Given this list of marker genes PHLDA1, GLE1, VRK1, NNT, WDR55, IGF1R, SLC35A4 (NCBI Gene Id 113829), NUDC, PAK1, ATP8B4, ANKRD13B, KIF2A, REXO2 (NCBI Gene Id 51640), HPRT1, SH3BP5, KIF20B, ZFAND1, FNTB, SEC61A1, COL5A1, ALOX15, TOMM40, DNAJC24, VARS1, KNTC1, LAIR1, TIPIN, FKBP4, EMILIN1, UGGT1, TOPBP1, PRIM2, NAP1L1, PITPNB, PANK1, EEF1E1, SUCLG2, TRMT1, MORF4L2, USP14, MSH2, XKR5, METTL24, FGF13, SAC3D1, TTC21B, ABCG2, PIGX, PTGES3, PNO1, OXSM, SOWAHB, DIS3, PAK1IP1, CAD, PPIL3, RPN1, NARS2, CHEK1, ATIC, NUP188, RSRC1 (arginine and serine rich coiled-coil 1), TOP2B, EIF4B, GSAP, SERBP1, CDC123, BUB3, TSEN54, COPRS, CD200R1L, MCM5, TIMM10, DARS1, FASN, SLC5A6, LMNA, C19orf48P, TBC1D2B, UBTF, BAMBI (NCBI Gene Id 25805), RRS1, MYADM, HEATR1, MYO19, PHTF2, PSMG2, TSFM, MANF, METTL16, CERS2, MYO1E, MAP4K5, CDR2, MAGOHB, YARS1, EMG1, FOXK2, TNF, CIMAP1A, SLC25A17, MCM3, RAD54L, RAP1A, CENPQ, EIF5A2, TPGS2, PSMD13, TCF3, FIRRE, SMDT1, ADAM17, CXCL3, CD48, PRXL2C, SETD6, PRMT7, KYAT3, GCSH, COTL1 (coactosin like F-actin binding protein 1), RNF150, ANGPTL4, CD163, DDHD2 (NCBI Gene Id 23259), TOP1MT, GLRX5 (glutaredoxin 5), MYCBP, PIN1 (NCBI Gene Id 5300), NUP37, FERRY3, PPA2, MBOAT1, ZMAT3, DIMT1, RRP15, SUCLG1, RRP1B, PALD1, MTAP, EIF3G, NCS1, CMKLR2, ORC6, CTPS1, HSPBP1, CLSTN1, CCT4, WDR18, PRPF31 (NCBI Gene Id 6106), UTP18, DFFB, DIAPH3, NPEPL1, NIP7, RUVBL1, NAF1, FAM217B, ABRACL, ARHGDIB, P4HB, RPS27L, OSGEP, NDUFAF2, POP1, IRF4, PRPS1, MCM4, RANBP1, UBTD2, TTC13, MDC1, YDJC, PAN3, DDX39B, METTL1, UBE2N, LIG1, PRC1, ATP5MC3, CREG2, YEATS4, MRPL20, COPS3, ATAD5, SREBF2, FUS, KIF23, TCP1, HINT1, HMGCS1, TMX4, CLEC5A, PPAT, SAMM50, TMEM109, H2AZ1, EMC6, NDUFA8 (NADH:ubiquinone oxidoreductase subunit A8), EMB, here is a description of the gene set: species: Homo sapiens Human Gene Set: GSE22432_CONVENTIONAL_CDC_VS_PLASMACYTOID_PDC_UP Genes up-regulated in dendritic cells: common versus plasmacytoid. from publication Felker P, Seré K, Lin Q, Becker C, Hristov M, Hieronymus T, Zenke M (PMID 20881193) Dendritic cells (DCs) in lymphoid tissue comprise conventional DCs (cDCs) and plasmacytoid DCs (pDCs) that develop from common DC progenitors (CDPs). CDPs are Flt3+c-kitintM-CSFR+ and reside in bone marrow. Here we describe a two-step culture system that recapitulates DC development from c-kithiFlt3-/lo multipotent progenitors (MPPs) into CDPs and further into cDC and pDC subsets. MPPs and CDPs are amplified in vitro with Flt3 ligand, stem cell factor, hyper-IL-6 and insulin- like growth factor-1. The four-factor cocktail readily induces self-renewal of MPPs and their progression into CDPs and has no self-renewal activity on CDPs. The amplified CDPs respond to all known DC poietins and generate all lymphoid tissue DCs in vivo and in vitro. Additionally, in vitro CDPs recapitulate the cell surface marker and gene expression profile of in vivo CDPs and possess a DC-primed transcription profile. Transforming growth factor-β1 (TGF-β1) impacts on CDPs and directs their differentiation towards cDCs. Genome-wide gene expression profiling of TGF-β1-induced genes identified transcription factors, such as interferon regulatory factor-4 (IRF-4) and RelB, that are implicated as instructive factors for cDC subset specification. TGF-β1 also induced the transcription factor inhibitor of differentiation/DNA binding 2 (Id2) that suppresses pDC development. Thus, TGF-β1 directs CDP differentiation into cDC by inducing both cDC instructive factors and pDC inhibitory factors.